Given this list of marker genes Cops7b, Pacs2, Myo18a, Pcnx1, Lipa, Maf, Pacs1, Slc41a1, St3gal1, Tdrp, Usp8, Mtcl2, Slc36a1, Pif1, Col1a2, Dag1, Msi2, Zfp202, Mon2, Myo10, Rnf222, Nmnat2, Tnpo2, Mllt10, Lrp4, Sarm1, Vat1, Nr2e1, Ugt2b37, C1qtnf6, Gpr155, Mgst3, Zer1, Phaf1, Plec, Clic5, Atrn, Ssr3, Nsun6 (NCBI Gene Id 74455), Sox5, Sec16a, Plxna3, Mgat5b, Adamtsl3, Ppp3r1 (NCBI Gene Id 19058), Pcgf3, Ube2i, Upf2, Smagp, Ogt, Mxi1, Nhsl3, Colgalt2, Smg1, Ugt2b5, Wdtc1, Crx, Gphn, Vac14, Pak1, Plxna4, Tvp23a, Etnk1, Actr3, Ctdnep1, Ubxn4, Tubb5 (tubulin, beta 5 class I), Vps26a, Ppargc1a, Mllt1, Cfap97, Cry2, Pank3, Acsbg2, Igsf23, Bahd1, Slc29a3, Slc37a2, Rd3, Sec24d, Tardbp (TAR DNA binding protein), Tcta, Adipor2, Sh3pxd2a (NCBI Gene Id 69633), Rps6ka2, Dpagt1, Lman2, Sox10, Sucla2, Smurf2, Grem2, Glce, St8sia2, Nucb1, Ccser2, Cldn12, Rab8b, Rbm4b, here is a description of the gene set: studied in species Mus musculus from publication Chen Y, Wang X (PMID 31504780) Mouse Gene Set: MIR_1962 Genes predicted to be targets of miRBase v22 microRNA mmu_miR_1962 in miRDB v6.0 with MirTarget v4 prediction scores > 80 (high confidence targets).